Given this list of marker genes PATZ1, WWC1, SCNN1A, SECISBP2L, HIC2, ADGRB2, ABCC3, HECTD4, GABBR2, CRELD1, TPM2, SLC16A3, VAPB, ITPR1, SORD, RAPGEF3, ZCCHC24, PPP1R13B, ID1, PI4KA, PPIL2, FBP1, ACADVL, SLC7A8, ELMO1, KIF5C, WFS1 (NCBI Gene Id 94141), RDH11, MFAP3L, TULP3, BASP1, ACAA1, EPB41L3, TP53I11, CNR1, PPARG, NID2, BNIP3L, PAN2, TOB2, IPCEF1, ATP10B, SYNE1, here is a description of the gene set: The demonstration of the PAX8-PPAR(gamma) fusion oncogene in a subset of follicular thyroid tumors provides a new and promising starting point to dissect the molecular genetic events involved in the development of this tumor form. In the present study, we compared the gene expression profiles of follicular thyroid carcinomas (FTCs) bearing a PAX8-PPAR(gamma) fusion against FTCs that lack this fusion. Using unsupervised clustering and multidimensional scaling analyses, we show that FTCs possessing a PAX8-PPAR(gamma) fusion have a highly uniform and distinct gene expression signature that clearly distinguishes them from FTCs without the fusion. The PAX8-PPAR(gamma)(+) FTCs grouped in a defined cluster, where highly ranked genes were mostly associated with signal transduction, cell growth and translation control. Notably, a large number of ribosomal protein and translation-associated genes were concurrently underexpressed in the FTCs with the fusion. Taken together, our findings further support that follicular carcinomas with a PAX8-PPAR(gamma) rearrangement constitute a distinct biological entity. The current data represent one step to elucidate the molecular pathways in the development of FTCs with the specific PAX8-PPAR(gamma) fusion. from publication Lui WO, Foukakis T, Lidén J, Thoppe SR, Dwight T, Höög A, Zedenius J, Wallin G, Reimers M, Larsson C (PMID 15608688) studied in species Homo sapiens Cluster 2: genes with similar expression profiles across follicular thyroid carcinoma (FTC) samples. Human Gene Set: LUI_THYROID_CANCER_CLUSTER_2